The following is a description of a gene set: Any process that activates or increases the frequency, rate or extent of multiplication or reproduction of fibroblast cells. species: Homo sapiens Human Gene Set: GOBP_POSITIVE_REGULATION_OF_FIBROBLAST_PROLIFERATION, and this is the list of marker genes: JUN (Jun proto-oncogene, AP-1 transcription factor subunit), FN1, WNT2, PML, FBLN1, AQP1, ABL1, DHX9, MYC, IL13, TGFB1 (transforming growth factor beta 1), CCNA2, BRK1, SIRT6, PDGFA, HTN3, PDGFB, FOSL2, ESR1, WNT5A, CDK6, PLA2G1B, NGFR, ITGB3, DDR2, CTC1, EGFR (epidermal growth factor receptor), FGF10, TGIF1, SPHK1, EREG, PDGFRA, CCNB1, CDKN1A, GAS6 (growth arrest specific 6), AGT, HMGA2, PDGFC, LIF, WNT1, PDGFD, CD74, HRAS, MIR17, ZMIZ1, RNASEH2B, CD248, MIF, MYB, IGF1, CDK4, E2F1, BMI1, S100A6, LIG4, BTC, CDC6